Given this list of marker genes ATP2A3, TP53I13, CXCR4, MED12L, IGHM, RABIF (RAB interacting factor), SPINT2 (NCBI Gene Id 10653), IL1R2, TRDD3, TAP1, KCNA3, PTCRA, IL4R, MECP2, PDE2A, TXLNGY, TMEM97, CMKLR1, RCSD1, HDAC9, SLC27A5, TTLL2, CACNG4, AMD1, CAPRIN1, PCSK4, CD200, C3orf36, FCRL1, SEL1L, XIRP1, HVCN1, BMX, ODF2L, RSAD2 (NCBI Gene Id 91543), FCRLA, DGKD, NME1, IL24, FCMR, FCER2, ZNF395, COL4A4, HMGN3, COL19A1, LZTS3, HSD17B11, KIAA0753, NEK11, VANGL1, TNFAIP2, MAP3K11, G6PC3, ABCC5, TOR1B, DBP, GABBR1, CNR2 (NCBI Gene Id 1269), TCL1A, CTSF, RUBCNL, ST7L, FGR, FOXP1, CD24 (CD24 molecule), DPEP2, BCL2, FADS3, UNC5D, ZFP36L2, NCOA3, SPPL2A, BACH2 (BTB domain and CNC homolog 2), PORCN, TCF7, FAM53B, PALM2AKAP2, BLK, TXNIP, RAPGEF6, MX1, CDC25B, ROR1, SOX6, MED29, UTY, PRMT3, BANK1, NTRK3 (neurotrophic receptor tyrosine kinase 3), MED25 (NCBI Gene Id 81857), MARCHF1, DIRAS2, PTX3, PTPRO (NCBI Gene Id 5800), ALOX5, SLC24A3, ICOSLG, USP2, ITGB7, ARHGAP4, SPON2, PNRC1, DEFA1 (NCBI Gene Id 504182), IRF8 (interferon regulatory factor 8), ZFHX2, TP53, BIN2, CD5, FCRL2 (NCBI Gene Id 79368), SHC2, CTLA4, here is a description of the gene set: Genes in the cancer module 145. species: Homo sapiens Human Gene Set: MODULE_145